Given this list of marker genes MAPT, VCP, TREM2, GALT, PSEN1, FOXP2, GRN, CHMP2B, TMEM106B, here is a description of the gene set: Human Gene Set: HP_DEFICIT_IN_GRAMMAR Deficit in grammar, including syntax and morphology. Deficit in grammar studied in species Homo sapiens